Given this list of marker genes SMARCE1, TAF4B, AKT1, PROP1, LHX4, RBM28, PDGFB, POU1F1, SMO, LHX3, HESX1, SMARCB1, GLI3, TRHR, PNPLA6, PIK3CA, GLI2, SOX3, TERT, DBH, SUFU, BAP1, ZMYND15, OTX2, GNAS, IGSF1, GCNA, NF2, FOXA2, TRAF7, here is a description of the gene set: Human Gene Set: HP_ABNORMAL_PROLACTIN_LEVEL Abnormal prolactin level studied in species Homo sapiens